The following is a description of a gene set: A change in the morphology or behavior of a myeloid leukocyte resulting from exposure to an activating factor such as a cellular or soluble ligand. species: Homo sapiens Human Gene Set: GOBP_MYELOID_LEUKOCYTE_ACTIVATION, and this is the list of marker genes: NR4A3, DYSF, STARD7, AIF1, TNIP2, CCL3, IL4, CD84 (CD84 molecule), CSF2, IRGM, PIK3CD, MIR142, LGALS9, CD93, LBP, SBNO2, PIK3CG, LILRB4, ADGRE2, CCR2, SPHK1 (sphingosine kinase 1), HYAL2, TMEM106A, IFNGR2, RHOH, CD2, NECTIN2, SLAMF1, RABGEF1, IFI35, CLNK, IGHE, CXCR2, CLEC4D, EDN2, HMGB1, HSPD1 (NCBI Gene Id 56733), SRC, TGFBR2, CD33, GATA2, WNK4, FAM76B, MCUB, AGER, JAK2, FGR, TLR9, TREX1, MFHAS1, MT1G, PJA2 (NCBI Gene Id 9867), PTPN11 (protein tyrosine phosphatase non-receptor type 11, NCBI Gene Id 84990), IL18 (NCBI Gene Id 3606), ADAM10, TRAF3IP2, RAC2, JUN, UNC13D, SNCA, ITGB6, SNX4, HAVCR1, ANXA1, RAB44, TLR3, DNASE1L3, MMP8, FN1, PRKCD, HAVCR2, PLA2G4A, MYO18A, MIR125A, PTGDS, SHPK, CLU, GAB2, WNT5A, SCN11A, PTPN6, CD37, ITGB2, CPLX2, RBPJ, CTSG, RORA, BATF2, IL31RA, VSIG4, IL13RA2, PTPRC, SYT11, DNASE1, MIR181C, CD74, GATA1, PLCG2, PRKCE, FES, F2RL1, MIR145, C5AR1, FCGR2B, TMEM229B, ENPP3, CRTC3, PSEN1, SNAP23, FCER1G, IL15, ADORA2B, VAMP7 (vesicle associated membrane protein 7), CXCL6, SUCNR1 (NCBI Gene Id 56670), CCL5, SCNN1B, FOXF1, SNX6, ANXA3, NR1H3, LRFN5, CD300A, KMT2E, NR1D1, IL10 (NCBI Gene Id 3586), VAMP3, KARS1, S100A12, GRP, C1QA, LAT, FCAR, TICAM1, NR4A1, SPI1, IL16, TSLP, VAMP8, BPI, IFNGR1, IL4R, CLEC12A, TTBK1, ZC3H12A, GPR137B, IFNG, ADAM9, NDRG1, CALHM2, STXBP1, PLPP6, MILR1, LILRA2, CBL, GPR15LG (NCBI Gene Id 387695, G protein-coupled receptor 15 ligand), PLSCR1 (phospholipid scramblase 1), RASGRP1, IL6, BATF, KIT, CD300LF, LCP2, NMI, IL13, JMJD6, CRLF2, KCNJ8, ITGB8, ADGRF5, TGFB1, NPY, ITGAM, MRGPRX2 (MAS related GPR family member X2), STAP1, MIR128-1, DHRS2, HSPA12A, STXBP3, NOTCH2, MAPT, IL18RAP, CD226, TLR4, RELB, FERRY3, CX3CR1, SYK, PLA2G10, FPR2, VAMP2, CHGA, GRN, THBS1, FER, DOCK2, IRF4, CSF1, TLR1, PRG3, NAGLU, PLA2G3, PREX1, TYROBP, CTSC, PTGDR, FCGR3A, BCR, CAMP, FOXP1, IL1RL1, UBD, CNR2, FCER1A, BTK, JUND, LAT2, MIF, MIR130A, LRRK2, STX4 (syntaxin 4), CD200, STK39, PYCARD, TNF, PTPRE, PDPK1, GKN2, TAFA3, FCER2, IL33, CD177, LDLR, DCSTAMP, BATF3, SPACA3, TSPAN32 (tetraspanin 32), CAMK4, LCN10, TLR6, CX3CL1, TREM2, SPHK2, SLC18A2, S100A13, LYN, STXBP2, CST7 (NCBI Gene Id 8530), TRAF6, CXCL8, APP, LTBR, SLC11A1, CEBPA, PLA2G2A, MYD88, PRAM1, AZU1